The following is a description of a gene set: Reactome Pathway: Chromosome Maintenance Maintenance of chromosomal organization is critical for stable chromosome function. part of: Cell Cycle species: Homo sapiens, and this is the list of marker genes: RPA1, CHTF8, CENPO, H2AB1, PIF1, POLR2H, RUVBL1, POLR2C, NHP2, TEN1, TERT, RUVBL2 (NCBI Gene Id 10856), HJURP, H2AJ, H2BC4, WRAP53, SMARCA5, H2BC17, CENPI, POLR2B, CTC1, CCNA2, CENPN, POLR2I, RPA3, H2BC1, CENPT, RFC4, POLR2J, H2AX, WRN (WRN RecQ like helicase), RFC2, ANKRD28 (NCBI Gene Id 23243), H2BC12L, CENPU, POLR2F, H2BC12, MIS18A, CDK2, H4C1, ACD, MIS18BP1, H3-4 (NCBI Gene Id 8290), TINF2, H2BC15, BLM, RBBP7, CENPS, POLR2G, H2BC9, CENPA, PRIM1, POT1, CENPW, DAXX, POLD2, H2BC14, TERF2IP, H2BC21, POLR2K, OIP5, CENPH, PRIM2, NOP10, RSF1, CENPP, ITGB3BP, NPM1, H2AC4, POLR2D, CENPM (centromere protein M), DSCC1, POLD4, POLR2A, H2AC20, POLA2, SHQ1, POLR2E, H2BC11, RPA2, RFC1 (replication factor C subunit 1), POLD1, POLD3 (DNA polymerase delta 3, accessory subunit), POLR2L, CCNA1, CENPL, TERF2, RBBP4, CENPQ, CENPC, H2AC7, H2BC13, CENPX, RFC3, GAR1, STN1, H2BC26, PPP6R3, DKC1, H2AC6, H3-3A, RTEL1, H2BC3, H2AZ2, H2AC18, H2AC14 (NCBI Gene Id 8331), PCNA, CHTF18, CENPK, KNL1, ATRX, TERF1, DNA2, POLA1, RFC5, PPP6C, LIG1, FEN1, H2BC5